Given this list of marker genes ICAM1, TFEC, IL7R, CXCL1, STAT4, TNC, SCARF1, TNFRSF4, IL1RN, ACVR2A, SLC7A5, PLAT, ATF5, CCL4, CCL3, TNF, CSF2, CCL8, TNFSF9, PLEK, ATP13A3, PTGER4, TRIM16, CD48, CCL20, CXCL8, PLA2G7, ISG15, KYNU, TLR2, NFE2L3, SOD2, GBP1, PLA2G4A, CCL5, RTN1, HCAR3, FKBP5, EDN1 (endothelin 1), SLC7A11, STAT1, NFKBIE, CREM, CCL1, MALT1, IL12B, GPR137B, TXNRD1, ENTPD1, CXCL11, CCL2, IL1B, SLC3A2, P2RX4, CXCL10, IL6 (interleukin 6), CXCL2, CD58, PSMA3 (NCBI Gene Id 5684), INHBA, RAB5A, here is a description of the gene set: species: Homo sapiens from publication Lindstedt M, Johansson-Lindbom B, Borrebaeck CA (PMID 12356685) Maturation of monocyte-derived dendritic cells (DC) in response to inflammatory stimuli: genes up-regulated only at 8 hr after the stimulation (cluster A). Human Gene Set: LINDSTEDT_DENDRITIC_CELL_MATURATION_A Maturation of dendritic cells (DC) serves a deterministic role in the link between innate and adaptive immunity, constituting a checkpoint with regard to whether responses from the lymphocyte compartment shall be raised and what class of response is needed to protect the host against invading pathogens. Since DC have not been shown to possess mechanisms such as gene recombination or somatic mutation for generating a diverse repertoire of antigen-recognition receptors, it is unlikely that these leukocytes can intrinsically respond to all conceivable molecules present in our environment. In the present study, we have therefore determined how mediators of the inflammatory response regulate global gene transcription in DC. The data represent an extensive and time-ordered reprogramming of the DC during their course of maturation, involving genes encoding proteins that regulate responses of both innate cells and lymphocytes. This transcriptional reorganization may reflect the effect of in vivo released inflammatory mediators induced by endogenous or pathogenic stimulation.